Given this list of marker genes PTGDR2, OXER1, PTGIR, PTGER3, GPR17, LTB4R, TBXA2R, CYSLTR1, PTGER2, PTGDR, PTGER1, LTB4R2, CYSLTR2, PTGER4, PTGFR, here is a description of the gene set: Human Gene Set: REACTOME_EICOSANOID_LIGAND_BINDING_RECEPTORS studied in species Homo sapiens Eicosanoid ligand-binding receptors